The following is a description of a gene set: Human Gene Set: HP_DEGENERATION_OF_ANTERIOR_HORN_CELLS Degeneration of anterior horn cells species: Homo sapiens, and this is the list of marker genes: EXOSC8, CEP126, SMN1, TFG, VRK1, IGHMBP2, AGTPBP1, SOD1, SMN2, ATXN3, NEFH, CPLANE1 (NCBI Gene Id 84157), EXOSC9, SETX, ASAH1, SLC25A46, ANXA11, PRPH, EXOSC3, DCTN1, UBA1